Given this list of marker genes CD96, EXTL3, SEC23A, CCND1, PUF60, TBC1D24, GNAQ, RASA1 (RAS p21 protein activator 1), PIK3CA, EIF2AK4, WNT5A, POR, ARL6IP6, DHCR7, VHL, DVL1, FGFR1, ESCO2, DIS3L2, CREBBP, MGAT2, KRAS, ANTXR1, GLI3, PTEN, DVL3, FLT4, RBM8A, HS2ST1, AKT1, CAPNS1, EP300, ATP6V1B2, GNA11, RECQL4, TRPM3, EPHB4, FZD2, KDR, here is a description of the gene set: The presence of a capillary hemangioma, which are hemangiomas with small endothelial spaces. species: Homo sapiens Capillary hemangioma Human Gene Set: HP_CAPILLARY_HEMANGIOMA